The following is a description of a gene set: The series of molecular signals mediated by hypoxia-inducible factor (HIF1) in response to lowered oxygen levels (hypoxia). Under hypoxic conditions, the oxygen-sensitive alpha-subunit of hypoxia-inducible factor (HIF)-1 dimerizes with a HIF1-beta subunit (also called ARNT or aryl-hydrocarbon-receptor nuclear translocator), translocates to the nucleus and activates transcription of genes whose products participate in responding to hypoxia. Mouse Gene Set: GOBP_HYPOXIA_INDUCIBLE_FACTOR_1ALPHA_SIGNALING_PATHWAY species: Mus musculus, and this is the list of marker genes: Pdk1, Vhl, Rwdd3, Cybb, Commd1, Hif1a, Pdk3